The following is a description of a gene set: Mouse Gene Set: GOBP_CELL_CYCLE_DNA_REPLICATION studied in species Mus musculus The DNA-dependent DNA replication that takes place as part of the cell cycle., and this is the list of marker genes: Donson, Zpr1, Dach1 (NCBI Gene Id 353035, dachshund family transcription factor 1), Brca2, Nuggc, Zfp830, Upf1, Aicda, Mcm6, Fbxo5, Atrx, Tk1 (NCBI Gene Id 21877), Ino80, Cdt1, Lig1, Gins1, Pola1 (NCBI Gene Id 18968), Rad51, Gmnn, Senp2, Rtel1, Dna2, Ilkap, Recql5, Dbf4, Wiz, Cdc7, Gins3, Rny3, E2f7, Atad5, Zmpste24, Mcm2, Mcm4, Mcm5, Mcm7, Mcm3, Rny1, Fgfr1, E2f8, Cdc45, Pcna, Rtf2